The following is a description of a gene set: studied in species Mus musculus Mouse Gene Set: GOBP_DETECTION_OF_STIMULUS_INVOLVED_IN_SENSORY_PERCEPTION The series of events involved in sensory perception in which a sensory stimulus is received and converted into a molecular signal., and this is the list of marker genes: Or5v1b, Or10g1b, Or12d13, Or2w2, Or2av9, Or10ak14, Or2h1b, Or4c3d, Tas2r115, Or2a14, Or10w1, Or10a3n, Or5g26, Or2a12, Or2a5, Tas2r121, Or5p76, Or10j3b, Or5p58, Or2g7, Tas2r130, Or10ab4, Or5t18, Or1r1, Tas2r116, Or2y17, Or5p60, Or5p4, Or6aa1, Or2ag2, Reep6, Or10aa3, Or2z9 (NCBI Gene Id 258532), Or2aa1, Azgp1, Tmem87a, Or13c7b, Rbp4, Or2ag1b, Or5p64, Comt, Or10a3, Tas2r138, Or12e10, Or2c1, Or5v1, Or10j5, Or5p66 (olfactory receptor family 5 subfamily P member 66), Or10h5, Tas2r119, Or10u4, Or10ak16, Or2t44, Or6n2, Ephb1, Grin2b, Or2w1b, Or2a20, Or2a56 (NCBI Gene Id 258650), Scn11a, Or2i1, Or5t9, Tas2r136 (taste receptor, type 2, member 136), Asic3 (NCBI Gene Id 171209), Nrg1, Or2t47, Or10al7, Or2t49, Ntrk1, Pkd1l3, Or2j6, Or10ag59, Or7r1, Sox2, Or2aj4, Or5an1b, Or2d2, Or10ag2, Or2l13, Tmc1, Or10a48, Tas2r139, Or5p70, Trpa1, Tas2r114, Or1j1, Or5k17, Or10n1, Or13p4, Or10j27, Or2b2, Col11a1, Tas2r103, Or2f2, Or8a1, Pdzd7, Or10j2, Slc24a4, Cxcl12, Or2y1b, Tnf, Or2a54, Or2v2, Il18, Or10al4, Or2aj6, Or10a4, Tas2r137, Rom1, Or5p57, Gja10, Cacna1f, Sema5a, Or2ag1, Or2b7, Or10am5, Or13e8, Or4b13 (NCBI Gene Id 406186), Tas2r106, Hpn, Tas2r134, Rho, Pcare, Or2y10, Or2w1, Or10p1, Or8g18, Or2b11, Or13p3, Or10ag56, Or2t1, Or10d5j, Or2w4, Or12d2 (olfactory receptor family 12 subfamily D member 2), Or4e1, Rest, Or2g25, Nr2f6, Or10g6, Kit, Asic2, Or10ak13, Or5an11, Adora1 (adenosine A1 receptor), Tas2r104, Or6n1, Tas2r140, Or13p10, Or6a2, Gm15433, Gucy2d, Or1j21, Or2f1b (olfactory receptor family 2 subfamily F member 1B), Ptprq, Or10ak7, Or2ad1, Tas2r117, Tas2r102, Or2t26 (olfactory receptor family 2 subfamily T member 26), Opn4, Or13c7c, Or2ag16, Or6ae1, Or12j5, Or6e1 (olfactory receptor family 6 subfamily E member 1), Tas2r110, Or2d3, Or2n1c, Or5p80, Or2a7, Or2m12, Or2t45, Or5p73, Or2h1, Best1, Rtp1, Slc12a2, Plcb2, Or5p52 (NCBI Gene Id 258770), Or6p1, Or10al2, Or5p1, Tmc2, Or5an6, Or2b28, Or12e13, Or2w3b, Or2j3, Rtp3, Pjvk, Grm8, Or56b34, Or10al5, Lxn, Or51e2, Kcnq1, Or10ah1-ps1, Or5h17, Or2bd2, Scrn3, Or2f1, Pcdh15, Tas2r125, Tas2r122, Or2l5, Or2o1, Or2d3c, Fyn, Or8u9, Or2ag18, Or8b8, Tas1r2, Or10d1, Or2ag17, Or2ak6, Or12e1, Gm7609, Or2a57 (olfactory receptor family 2 subfamily A member 57), Or10ab5, Or13n4, Or2y6, Chrna5, Or2b4, Chrna10, Cacna2d4, Or8g50 (NCBI Gene Id 277998), Or10p22, Trpv1, Or2t43, Or5p59, Or10ag53, Or5j3, Or4e2, Chrna9, Or10d4b, Or10j3 (NCBI Gene Id 404511), Tas2r108, Or6b9, Gm7582, Car6, Tas2r118, Or2ak7, Or10a3m, Or13c7d, Vmn2r1, Rtp2, Scn9a, Pawr, Or10c1 (NCBI Gene Id 258506), Or10a3b, Or12j2, Or2r3, Mkks, Tas2r126, Or10h1, Crb1, Or5g9, Or10ac1, Or12k8, Or2z8, Or10ag57, Or2aj5, Or5h19, Grin2d, Or2y1, Bace1, Or2w25, Or5k16, Grm6 (glutamate receptor, metabotropic 6), Or6k2, Rtp4, Or2k2, Cacnb3, Or5p69, Htr2a, Kcnk2, Pip, Or2l13b, Or7e178, Or9s13, Or2a52, Or8c8, Or10g9b, Prph2, Or2t46, Or12k5, Piezo2, Or13a1, Or10ag58, Or2y1f, Or2b6, Or10a49, Vmn2r26, Or2n1, Or1e16, Or2h2, Igf1, Arrb2, Or2d4, Or10k2, Or10d1c (NCBI Gene Id 258434), Kcna1, Grin2a, Rpe65, Or2y3, Or2ab1, Or5an1, Or1m1, Or2g1, Or2v1, Ppef1, Or2y15, Or6y1, Or10aa1 (olfactory receptor family 10 subfamily AA member 1), Or2ag13, Tas2r124 (NCBI Gene Id 387351), Or2t48, Rgs9bp, Or10d4, Or5an10, Or12d15, Cngb1, Or2ag12, Ccdc66, Or12d14-ps1, Or12e9, Or10ag60, Or10al6 (olfactory receptor family 10 subfamily AL member 6), Or10h1b, Pkd2l1, Cacnb4, Or2y8 (NCBI Gene Id 211472), Or10h28, Or13p8, Itga2, Or5g29, Gnat3, Or10u3, Sema5b, Myc, Or9g19, Or13c7, Gnat1, Tac1, Strc, Or5p68, Or2y14, Tas2r113, Or10d3, Or13d1, Or5ap2, Or10al3, Or5ar1, Or2ag19 (olfactory receptor family 2 subfamily AG member 19), Or5p51, Tas2r144 (NCBI Gene Id 387515), Or10ad1, Or2a25, Or2h2c, Or2r2, Or2z2, Or2n1e, Or6k6, Or2y16, Or5p6, Or5p81 (NCBI Gene Id 258308), Or6k4, Or5p53, Or2ag20, Or2h15, Whrn, Ffar4, Atp8a2, Or2w3, Tlr4, Or10ag54, Or10g3b, Or2r11, Ano1, Or12d16-ps1, Tas2r131, Or6b13, Or5p54, Or10ak12, Scn10a, Or5p62, Or13f5, Or5h18, Or10s1, Or5p50, Tas2r135, Ntsr1, Adgrv1, Or5d20-ps1, Or2t6, Or10ag52, Or2n1b, Or2ah1, Or10ak11, Or12d17, Tas1r3, Or2d36, Tas2r105, Or10ak9 (NCBI Gene Id 258159), Tas2r107, Or13c25, Or2w6, Or2y11, Or4e5, Or2t29, Gnat2, Tmem120a, Mmp24, Or13ae2, Or5p67, Or10ak8, Or2ag15, Prdm12, Tas2r120, Or7a42, Tas2r109, Or2d2b, Or10a5, Lhfpl5, Or5an1c, Tulp1, Cep250, Or13p5, Or5g25, Or8g17, Ppef2, Or5t17, Or10d5, Or5p79 (NCBI Gene Id 258738), Disc1, Or10j7, Wdr47, Or13g1, Or8u3-ps, Or2t35, Or5p55, Or12e7 (NCBI Gene Id 258834), Or2q1, Or13c3, Or2b2b, Or12d12 (olfactory receptor family 12 subfamily D member 12), Or10g3, Or5b21, Or2y12, Or6k14, Scn1a, Or6z7, Or2ag2b, Lpo, Calca, Or2ak5, Tac4, Or2m13, Or2a51, Phf24, Grik2, Or2y1e, Gucy2f, Pigr, Or10ad1b, Htr7, Or2y1d, Or2y1g, Tas2r129, Or12e14, Or10d1b, Or2n1d, Or7a40, Or5p56, Or12e8, Or10g9, Or7d11, Tas2r143, Or5p72, Or5t7, Or2p2, Or2ak4, Or2y1c, Or3a10, Or12j4, Or6b1, Or5an9, Or11i1, Or10g7, Or8b3, Or2d3b, Or13j1, Or10d4c, Or5m5, Or11m3, Or10g1, Kcnk4, Tas2r123, Serpine2, Or10a2, Or4m1, Cxcr4, Or2y13, Atp2b2, Or10z1, Or12j3